Given this list of marker genes Ccdc39, Spag6l (NCBI Gene Id 50525), Dnaaf3, Ulk4, Cfap221, Daw1, Cfap54, Jhy, Aqp4, Dnaaf11, Spef2, Gmnc, Nherf1, Cfap45, Cwh43, Cfap53, Dnah9, Cfap43, Katnip (NCBI Gene Id 272436), Odad4, Odad3, Spag16, here is a description of the gene set: Mouse Gene Set: GOBP_CEREBROSPINAL_FLUID_CIRCULATION species: Mus musculus The neurological system process driven by motile cilia on ependymal cells of the brain by which cerebrospinal fluid circulates from the sites of secretion to the sites of absorption. In ventricular cavities, the flow is unidirectional and rostrocaudal, in subarachnoid spaces, the flow is multi-directional.